Given this list of marker genes ASL, here is a description of the gene set: Reactome Pathway: ASL variants cause argininosuccinate aciduria Argininosuccinate lyase (ASL) is a homotetrameric enzyme that catalyzes the fourth reaction of the urea cycle, the cleavage of argininosuccinate to arginine and fumarate. Mutations in ASL cause argininosuccinic aciduria (OMIM 207900), an autosomal recessive disorder that affects 1:70,000 to 1:218,000 live births. Like other disorders of urea cycle enzymes, argininosuccinic aciduria is clinically diverse, with a severe neonatal form characterized by hyperammonemia, encephalopathy and respiratory alkalosis and a milder, late onset form that may be triggered by stress or infection. Late onset alleles of ASL often retain residual activity, with heterozygous mutations interacting in vivo to restore a functional active site through intramolecular complementation. part of: Diseases of the urea cycle studied in species Homo sapiens